Given this list of marker genes Hes1, Tgif2, Gdf11, Pou4f2, Casz1, Tgif1, Dlx1 (distal-less homeobox 1), Dlx2, here is a description of the gene set: Any process that modulates the frequency, rate or extent of amacrine cell differentiation. species: Mus musculus Mouse Gene Set: GOBP_REGULATION_OF_AMACRINE_CELL_DIFFERENTIATION